The following is a description of a gene set: studied in species Mus musculus Mouse Gene Set: GOBP_POSITIVE_REGULATION_OF_UBIQUITIN_DEPENDENT_PROTEIN_CATABOLIC_PROCESS Any process that activates or increases the frequency, rate or extent of ubiquitin-dependent protein catabolic process., and this is the list of marker genes: E330034G19Rik, Det1, Zyg11b, Rack1, Fbxw7, Dda1, Socs4, Csnk1a1, Cdk5rap3, Pabir1 (PP2A A alpha (PPP2R1A) and B55A (PPP2R2A) interacting phosphatase regulator 1), Egf, Agbl4, Aurka, Atg7, Rnf139, Mapk9, Rnf180, Axin2, Akt1, Trib2, Socs5, Mtor, Ube2v2, Stub1, Fbxo22, Sumo2, Csnk1e (casein kinase 1, epsilon), Ptk2b, Rbx1, Trib1, Hspa1a, Psmd10, Agtpbp1, Cop1 (NCBI Gene Id 98306), Prkn, Rchy1, Paqr3 (NCBI Gene Id 70746), Sirt1, Hspa1b, Trim67, Nub1, Mapk8, Sirt6, Rad23a, Ptk2, Herpud1 (homocysteine-inducible, endoplasmic reticulum stress-inducible, ubiquitin-like domain member 1), Cdc20, Ccdc22, Nop53, Dnajb2, Vcp, Plk2, Plk3, Psen2, Klhl40, Rbx1-ps, Chfr, Dab2, Trib3, Gsk3b, Csnk1d, Traf7, Gclc, Pias1, Sh3rf2, Ddrgk1, Sirt2, Axin1, Trf, Pten, Sumo3, Sh3rf1, Hamp, Atxn3, Gsk3a, Usp5 (ubiquitin specific peptidase 5 (isopeptidase T)), Smurf1, Nkd2, Bag2, Fzr1, Dvl1, Laptm5, Fbxw8, Psen1, Zer1, Sgta, Bcap31 (B cell receptor associated protein 31), Sh3rf3, Cdc20b, Lrrk2, Plk1, Bbs7, Sumo1, Cbfa2t3, Prickle1, Mdm2, Hspbp1, Clu, Il33, Gba1, L3mbtl3, Zfand2a, Tgfb1i1, Gabarap (NCBI Gene Id 56486), Disc1